The following is a description of a gene set: species: Homo sapiens Genes up-regulated in comparison of dendritic cells (DC) stimulated with Pam3Csk4 (TLR1/2 agonist) at 24 h versus DC cells stimulated with CpG DNA (TLR9 agonist) at 24 h. from publication Amit I, Garber M, Chevrier N, Leite AP, Donner Y, Eisenhaure T, Guttman M, Grenier JK, Li W, Zuk O, Schubert LA, Birditt B, Shay T, Goren A, Zhang X, Smith Z, Deering R, McDonald RC, Cabili M, Bernstein BE, Rinn JL, Meissner A, Root DE, Hacohen N, Regev A (PMID 19729616) mouse primary BMDCs were stimulated with tlr ligands and gene expression changes were profiled on Affymetrix arrays Human Gene Set: GSE17721_PAM3CSK4_VS_CPG_24H_BMDC_UP, and this is the list of marker genes: PGRMC2, KCNJ2, ZHX1, HOXC5, PRCP, IL17RC, ZNF704, CLDN1, MMD2, FAS, IDH1, HACL1, S100B, FIS1, RORA, YIPF1, SERPINI1, MRPS21, PCDH1, RPLP0, SLC7A1, BNIP3L, LTBP3, PXMP4, MYL12B, PDCD4, XPR1, EREG, TMEM176B, AANAT, GJA1, EMC2, SOX4, EIF3M (eukaryotic translation initiation factor 3 subunit M), UQCR10, CFAP157, PPP1R3A, CHODL, AP2A2, GCLM, H2AZ1, ESYT3, SLC11A1, NUCKS1, MFSD6, FGF1, RAB9A, ADCK1, TOM1, PTPN1, NDUFA10, FZD3, LUZP1, SLC37A3, STARD4, FOXD4L1, ATP5ME, RPLP2, SLC35C1, EFNB2, PIAS4, SLC25A48, HACD2, ATOH7, SLC12A2, SYT4, FOXB1, NCMAP, NME1, TMEM165, SPINT1, PABPC1, PRKD3, PILRB (NCBI Gene Id 29990), GLB1L, CILP2, GTSF1L, NT5C3B, METRNL, NDUFV3, CYP51A1, SHANK3, CNNM2, UCHL1, ZFP36L1, TRUB2, EAPP, LPIN1, IQGAP2, TOR2A, CHDH, PDIA3, NQO2, ZBTB8OS, BCAP31, SLC35B3, CD163 (CD163 molecule), HLF, COL1A1, MYOZ3, NANOS1, DDX59, SELENON, AP1S2, ATP7B, SPTA1, SHC1, TNFRSF21, VAV2, CDC25B, CAPZA3, TPRG1L, ARG1, TREM1, EDEM1, FOXL1, S100A9, EEF1D, ETFB, ACTR10, BUB1, MCAM, MAN1A1, ACOX1, PTPRU, ELMO2, COX16, DCTN3, THYN1, ATP5MC1, MAPK3, JTB, COL4A4, ADAD1 (adenosine deaminase domain containing 1), SCCPDH, PALLD, TMCO1, NADK, CCDC12, AGRP, NKX2-4, AMACR, EEF1B2, NLRP3, UBA1, UCN, COX8A, EGFL8, ARHGAP45, TBC1D10A, CWC15, SAG, CD2BP2, WDR45, APOBR (NCBI Gene Id 55911), ADAMTS8, PCYT2, SCARA5, BLVRA, RASAL3, ATP5MC2, PPP1R10, POGLUT2, CTSV, SORCS3, HSD17B8, DELE1, CEP290, SFR1, TUBA4A, FHL2, RPL10, APOC2, TMEM45A, STRA6, TRAT1, RAB7A, INTS6L, TPRA1, PCDHB13, TMEM243, DNTTIP2 (NCBI Gene Id 30836), HOXD10, TECR, EARS2, RPL6, MMP2, GUK1, GRK5, FDPS, CHRNA6, WSB2, HCCS (holocytochrome c synthase), KIF1C, ALDH3A2, CS, XPC, UQCRFS1, NCK1, RPL36A